The following is a description of a gene set: from publication Chen Y, Wang X (PMID 31504780) Genes predicted to be targets of miRBase v22 microRNA mmu_miR_6906_3p in miRDB v6.0 with MirTarget v4 prediction scores > 80 (high confidence targets). studied in species Mus musculus Mouse Gene Set: MIR_6906_3P, and this is the list of marker genes: Ddx19a (DEAD box helicase 19a), Arid1b, Fos, Ddx19b, Zw10, Rnf115, Arl3, Sp4, Foxk2, Eef2